Given this list of marker genes TRIM34, IFIT3, ZDHHC11, SPON2, DNAJC3, RB1CC1, OAS1, RIGI, VAPB, NMB, IL33, GPR108, ITGAX, IFIT1B, IFNA8, IRF3, IFNA7, IRF9, ELMOD2, USP44, DHX16, SETD2, BCL2, TBK1, PPM1B, GBP1, IFNA1, IFIT1, TRIM32, OAS2, SLFN11, IFI6, IFNA5, DDIT4, IFNA17, POLR3K (NCBI Gene Id 51728), MX1, RNF26, CHMP3, BCL2L1, LSM14A, CD37 (CD37 molecule), IFNA14, ERCC6 (ERCC excision repair 6, chromatin remodeling factor), TRIM6, GPR146, OAS3, AICDA, EXOSC5, NDUFAF4, IFI16, IFIH1, TRIM5, AGBL4, TREX1, OPRK1, MUL1, IFNA21, CREB3, GBP3, GARIN5A, PQBP1, ZDHHC11B, RELA, SERINC3, AIM2, TRIM38, CD207, IL10RB, IFNGR2, DTX3L, DHX9, FCN3, TRAF3IP2, ATG7, AKAP1, SMARCA5, TLR3, DEFA3, BNIP3, ABCC9, CRCP, MICA, MID2, DHX58, ATAD3A, IRF1, IL12B, POLR3A, TRAF3IP1, IL23A, VAMP8, IRGM, BST2 (bone marrow stromal cell antigen 2), IFITM2, ADARB1, BNIP3L, DEFA1, APOBEC3C, RAB2B, OASL, PMAIP1, ATG5, TARBP2, CCDC92, IFIT5, ZMPSTE24, CGAS, ABCF3, NT5C2, TLR8, ILF3, RSAD2, PHB1, KCNJ8, IL15, RNASE1, MLKL, MMP12, USP18, MAP3K14, IL1B, RIOK3, ZBP1, EIF2AK2, PARP9, MIR26B, MOV10, IFNG, APOBEC3G, NLRP6, APOBEC3A, IFITM1, TRAF6, ZNFX1, SELENOK, RTP4, DHX15, IFNA16, IFI44L, NMBR, ACOD1, SERINC5, TOMM70, RNF185, TRIM8, AZU1, IL27, IFNW1, DDX60L, MICB, SENP7, CD40, PDE12, UBE2W, IFNL3, IFNL1, USP27X, UBE2N, MYD88, TRIM11, MAVS, IFNLR1, IRF5, ZNF175, TRIM27, TRIM21, TSPAN32, DDX21, RIPK3, UAP1 (UDP-N-acetylglucosamine pyrophosphorylase 1), MORC3, DDX17, CARD8, ATG16L1, IL12RB1, RNASE6, ZMYND11, POLR3E, ZCCHC3, ZDHHC1, HYAL2, CARD9, CXADR (CXADR Ig-like cell adhesion molecule), CNOT7, DUS2, POLR3H, IRF2, IFIT2, DDX60, TNFAIP3, IFNL4, ISG15, GBP2, APOBEC3B (NCBI Gene Id 9582), DEFA1B, PLA2G10, SAMHD1, UNC13D, IL23R, IFNB1, USP17L2, CLPB, DHX36, IFNE, TRIM26, TMEM120A, FOXP3, AGBL5, EIF2AK4, TRIM15, SIN3A (SIN3 transcription regulator family member A), FGL2, NLRC5, IFNA4, TRIM56, EXOSC4, NCK1, STAT2, PRF1 (NCBI Gene Id 5551), RNF216, PML, TRAF3, IFNA2, TRIM25, BPIFA1 (BPI fold containing family A member 1), TBKBP1, APOBEC3F, IL6, POLR3C, ZC3HAV1, PLSCR1, F2RL1, IFNK, HDAC6, PYCARD, GBP5, GPAM, APOBEC3D, TANK, STING1 (NCBI Gene Id 340061), PRKRA, ZC3H12A, UBL7, RNASE2, TLR2, LYST, EXOC1, USP20, IFI27 (interferon alpha inducible protein 27), TTC4, POLR3B, OTUD4, DDX56, UNC93B1, IFITM3, TRIM65, TLR9, POLR3G, EPG5, IFNGR1, ILRUN, ADAR, DDX1, MX2, TNF, SHFL, SLFN13, NLRP1, NT5C3A, BECN1, APOBEC3H (NCBI Gene Id 164668), TRIM41, NLRP9, HCFC2, NCBP1 (NCBI Gene Id 4686), PTPRC, ARMC5, IL21, TRIM35, POLR3F, TRIM31, TRIM7, USP29, TLR7, GBP7, IKBKE, ATG12, CXCL10, ATG14, TRIM13, IFNA6, POLR3D, SKP2, TRIM28, C1QBP, TICAM1, MARCHF2, RNASEL, HSP90AA1, FADD, PCBP2, IFNAR2, RNF135, CXCL9, DDX41, DMBT1, G3BP1, LILRB1, AZI2, STAT1, ISG20, IFNL2, PHB2, IFNA10, TRIM22 (NCBI Gene Id 10346), CASP1, ITCH, SPN, IRF7, HERC5, NCBP3, TRIM44, MBL2, RPSA, TRIM52, AIMP1, here is a description of the gene set: Human Gene Set: GOBP_DEFENSE_RESPONSE_TO_VIRUS Reactions triggered in response to the presence of a virus that act to protect the cell or organism. studied in species Homo sapiens